Given this list of marker genes HTN1, TLN1, PBX1, CLASP1, SLITRK2, FIGN, GPR82, PTMS, SESN3, RORB, TRPS1, LRRTM3, SLC43A3, TLE4, CPEB4, GDNF, RNF122, PRL, TNKS1BP1, RBMS2, JAKMIP2, PRICKLE2, SIAH3, BMI1, HIVEP2, PDE4B, EIF2B4, COL4A3, HSD3B7, PRDM10, ASB11, PDP1, CREB5, BRCA2, TAFA1, FIZ1, SULF1, MSS51, RASAL2, HCN4, KCNIP4, PBXIP1, ATOSB, PRG4, CYP2F1, JMJD1C, PRRT1 (NCBI Gene Id 80863), VSIG1, COL2A1, SOX4, LRRC15, HRK, ACTN3, ZNF516-DT, RXRG, RAX (retina and anterior neural fold homeobox), BCL11A, AANAT, MSX1, CTCF, PNPLA3, HPSE2, AMELX, TTC9C (tetratricopeptide repeat domain 9C), RIN2, MEIS2, DLC1, PDE7A, SLC29A3, PPM1L, PRKCE, SEMA5B, SNX17, SHOX2, CREB3, NR2E1, ENSG00000204117, MEOX2, CELF4, BEST3, NDST4, FOXN3, GUCY2F, CGGBP1, SLC25A28, ASPA, KCNQ1DN, DUSP10 (NCBI Gene Id 11221), PPT2, TWIST1, CASK, TMED7, VEZF1, EMX2, MRPL58, KLK9, MFRP, PDLIM7, MYPN (NCBI Gene Id 84665), NCALD, ARMH4, RNF43, USPL1, ZBTB18, PRDM1, FGF16, SLC35A2, ASCL4, TMEM100, BAHD1, ADAMTSL1, FOSL2, SLC26A9, SOX14, RFX4, ZBTB10, PYY2, HOXA3, GSK3B, TNNC1, KRT3, SPTSSB, PIK3R5, MAB21L1, BMPR2, OMG, HOXB4, HMGB1, SOWAHC, ODF2, IGSF21, NEFL, LIN28A, SREK1, MYLK, JOSD1, TAPBP, ZBTB7A, ERBB3, CRNN, FAF1, CREBZF, TRIB1, SORBS2, MBD6, SPACA9, BNC2, CD2AP (NCBI Gene Id 25916), GADD45G, SLC13A1, DPYSL5, TMEM132E-DT, EGFLAM, GRIN2B, TUBA8, UNC13B, HOXA2, MANEAL, RP1, SNX6 (NCBI Gene Id 58533), DNAH11, NPPC, DST, KCTD15, SH3BGRL3, LTBP1, KMT2E, ADORA1, ADGRL2, NDRG2, MYOG, RORA, JOSD2, KCNJ15, LUC7L3, TICAM2, PITX2, HESX1, ABI3BP, MIP, ADNP, FZD6, ACVR1, FAM53C, CDK2AP2, NCOA2, LINC00310, SLC39A2, PURA (purine rich element binding protein A), NCOA3, N4BP2, NTRK2, PMFBP1, TMEM132E, PSMA8, MED13, MITF, KITLG, KLHL41, RUNX1, NDUFS2, AMELY, NFIX (nuclear factor I X), GPR158, ROBO3, GAD1, GKN1, PMCH, GLRA1, CPNE1, IL2, UBE2E4P, APP, PYY, SCN2A, FES, CDH11, BCL2, ZDHHC12, AK8, FZD4, CACNA2D3, OLFML1, ALG13, TIGD2, FBXL19-AS1, FOXO4, ORC4, ADAMTS4, TCF21, SEPTIN10, DCTN4, PRSS33, FAM89B, OR2L13, NPTX2, IER5, FOXP2, SLC41A2, LMO4, CRYGS, SLITRK5, SLC37A4, BARHL1, MYB, AQP5, DDX17, PDGFA, RALYL, RYBP, UBE2N, PLXNA2, BMP4, HOXA1, RMDN2, EYA1, PIANP, PRDM8, RBPMS, C16orf74, LRP6, COL4A4, BAMBI, HNRNPD, here is a description of the gene set: Human Gene Set: PITX2_Q2 Genes having at least one occurrence of the motif WNTAATCCCAR in the regions spanning 4 kb centered on their transcription starting sites. This matches the PITX2 transcription factor binding site V$PITX2_Q2 (v7.4 TRANSFAC). species: Homo sapiens